The following is a description of a gene set: In this study, an extensive analysis was conducted to define meta-programs (MPs) capturing intra-tumor heterogeneity across a spectrum of tumor types. The approach utilized non-negative matrix factorization (NMF) to analyze each cell type separately within individual tumor samples. This involved the analysis of malignant cells, macrophages, fibroblasts, endothelial cells, epithelial cells, T-cells, and B-cells. NMF was executed with varying parameter values (K=4, 5, 6, 7, 8, 9), thereby generating 39 programs for each cell type per sample. Each NMF program was summarized by the top genes based on NMF coefficients.\nRobust MPs were then delineated for each cell type using a set of stringent criteria, including recurrence within the same tumor, similarity to programs in other tumors, and non-redundancy within a tumor. Subsequently, these robust NMF programs were clustered (per cell type) based on Jaccard similarity, leading to the identification of MPs associated with each cell type.\nTo enhance the quality of the MPs, a refinement steps were undertaken, involving the removal of MPs suspected of reflecting low-quality data (with an overrepresentation of ribosomal proteins or mitochondrial-encoded genes), single-study inclusion, or similarity to miss-annotated cell types. species: Homo sapiens Genes upregulated in subsets of cells of a given type within various tumors from publication Gavish A, Tyler M, Greenwald AC, Hoefflin R, Simkin D, Tschernichovsky R, Galili Darnell N, Somech E, Barbolin C, Antman T, Kovarsky D, Barrett T, Gonzalez Castro LN, Halder D, Chanoch-Myers R, Laffy J, Mints M, Wider A, Tal R, Spitzer A, Hara T, Raitses-Gurevich M, Stossel C, Golan T, Tirosh A, Suvà ML, Puram SV, Tirosh I (PMID 37258682) Human Gene Set: GAVISH_3CA_METAPROGRAM_MACROPHAGES_PROTEASOMAL_DEGRADATION, and this is the list of marker genes: SDF2L1, FCGR1A, HSPA5, PRDX1, S100A8, PDIA6, CYP27A1, PLA2G7, RENBP, TUBA1A, PSMD7, HM13, MDH1, DNASE2, MANF, LGALS3, CALR, NAGK, FBP1, MNDA, TREM2, S100A9, PSMC2 (NCBI Gene Id 5701), VSIG4, PSMA5, PSME2, GLIPR2, PSMC3, MGST3, PSMB6, CD9, FABP5, FPR1, CCT5, MARCO, LTA4H, HSP90B1, CCL2, ATP6V0D1 (ATPase H+ transporting V0 subunit d1), PSMA4 (proteasome 20S subunit alpha 4), PSMA3, CTSL, LRPAP1, SLC3A2, GCHFR, MYDGF, NME1, PSMD8, TUBA1B, SPP1